Given this list of marker genes RING1, TEX10, RNF2, H3-3A, PCGF3, PCGF5, FBRS, DCAF7, EP300, RYBP, H3C1, H3C2, H3-3B, YAF2, AUTS2, here is a description of the gene set: Transcriptional activation by acetylation of H3K27. Pathway ID: N01701. Pathway type: Reference. Pathway class: nt06523 Epigenetic regulation by Polycomb complexes. Human Gene Set: KEGG_MEDICUS_REFERENCE_TRANSCRIPTIONAL_ACTIVATION_BY_ACETYLATION_OF_H3K27 studied in species Homo sapiens Pathway Definition from KEGG: PRC1.3,PRC1.5 == TEX10+EP300 -- H3 -> H3K27ac